The following is a description of a gene set: Genes down-regulated in monocyte 7d vs 0d in young adults (18-50) after exposure to Fluarix/Fluvirin, time point 7D Here we have used a systems biology approach to study innate and adaptive responses to vaccination against influenza in humans during three consecutive influenza seasons. We studied healthy adults vaccinated with trivalent inactivated influenza vaccine (TIV) or live attenuated influenza vaccine (LAIV). TIV induced higher antibody titers and more plasmablasts than LAIV did. In subjects vaccinated with TIV, early molecular signatures correlated with and could be used to accurately predict later antibody titers in two independent trials. Notably, expression of the kinase CaMKIV at day 3 was inversely correlated with later antibody titers. Vaccination of CaMKIV-deficient mice with TIV induced enhanced antigen-specific antibody titers, which demonstrated an unappreciated role for CaMKIV in the regulation of antibody responses. Thus, systems approaches can be used to predict immunogenicity and provide new mechanistic insights about vaccines. species: Homo sapiens from publication Nakaya HI, Wrammert J, Lee EK, Racioppi L, Marie-Kunze S, Haining WN, Means AR, Kasturi SP, Khan N, Li GM, McCausland M, Kanchan V, Kokko KE, Li S, Elbein R, Mehta AK, Aderem A, Subbarao K, Ahmed R, Pulendran B (PMID 21743478) Human Gene Set: NAKAYA_MONOCYTE_FLUARIX_FLUVIRIN_AGE_18_50YO_7DY_DN, and this is the list of marker genes: CHMP1B, BIN3, SGPL1, TMEM97, PLPPR2, TRAF3IP3, VRK2, SIK1, YRDC, CXCR4, POLG, SLC2A3, KSR1, SLC2A14, GALC, IL15RA, CREM, GABARAPL1, PLCB1, RFC5, PLK2, ARG2, PEX6, SPATA6, ABCC1, ADNP2 (NCBI Gene Id 22850), NID1, KLHL7, CFLAR, C5AR1, EGR3, NOCT, CCPG1, FCAR, VEGFA, LAS1L, PCSK5, DESI2, TAF4, PDE4B, TNFSF13, UBE3B, ESYT1, CAMSAP1, TCF7L2, XRCC1, KLF7, VPS37A, PMVK, CLEC4A, TGIF1, GLYR1, DCLRE1B (NCBI Gene Id 64858), EXOC5, SPRY1, FAM110B, TMCC1, PLAGL2 (PLAG1 like zinc finger 2), ARNT, KDM4B, PPARD, NXPE3, DOCK5, RUSC1, GNA13, WDR59, ZNF331, CUL5, HBEGF, SLFN12, CD44, SLC44A1, RDX, PRDM1, TRAM2, ABCA1, SAT1, CDC42EP4, KBTBD11, THBS1, RNF41, VNN1, RFWD3, SLC22A4, GIT2, NAMPT, PIN4, EPB42, DMXL2, IRS2, RASA1, PER1, HOXA2, TNFSF12-TNFSF13, ERAP2